The following is a description of a gene set: Most patients with acute myeloid leukemia (AML) enter complete remission (CR) after treatment with chemotherapy, but a large number of them experience relapse with resistant disease. To identify genes that are associated with their prognoses, we analyzed gene expression in 54 pediatric patients with AML using an oligonucleotide microarray that contained 12 566 probe sets. A supervised approach using the Student t test selected a prognostic set of genes, some of which are associated with the regulation of cell cycle and apoptosis. Most of these genes had not previously been reported to be associated with prognosis and were not correlated with morphologically classified French-American-British (FAB) subtypes or with karyotypes. These results indicate the existence of prognosis-associated genes that are independent of cell lineage and cytogenetic abnormalities, and they can provide therapeutic direction for individual risk-adapted therapy for pediatric AML patients. Genes associated with clinical prognosis of pediatric AML (acute myeloid leukemia): good prognosis=no relapse > 3 years; poor prognosis=relapse < 1 year or no response to therapy. studied in species Homo sapiens from publication Yagi T, Morimoto A, Eguchi M, Hibi S, Sako M, Ishii E, Mizutani S, Imashuku S, Ohki M, Ichikawa H (PMID 12738660) Human Gene Set: YAGI_AML_RELAPSE_PROGNOSIS, and this is the list of marker genes: NFKBIA, ENSA, KAT2A, GRIK5, NME1, AZU1, LUZP1, VDAC1, HSPE1, HNRNPD, XPO1, TYMP, TIAL1, LBR, TSPO, TKT, GABARAP, BST1, ZYX, CLIP2, RAB32 (RAB32, member RAS oncogene family), CD68, APLP2, TUG1, OGT, NPC2, VAT1, CDK6, PTP4A2, ATP6V0B, CD14, POLR2H (RNA polymerase II, I and III subunit H), ECE2, PGD, HOMER3